The following is a description of a gene set: Human Gene Set: GOMF_G_QUADRUPLEX_RNA_BINDING species: Homo sapiens Binding to a G-quadruplex RNA structure, in which groups of four guanines adopt a flat, cyclic hydrogen-bonding arrangement known as a guanine tetrad., and this is the list of marker genes: AFF2, MCRS1, XRN1 (NCBI Gene Id 54464), GRSF1, LIN28A, FMR1 (NCBI Gene Id 5421), DHX30, DHX36